Given this list of marker genes Cxcl1, Acp3, Fabp5, Atp8b4, Slc44a2, Faf2, H2-M3, H2-Q6, Rab5b, Cat (NCBI Gene Id 269322), Cnn2, Arhgap9, Psmd3, Prss3, Fuca1, Cap1, Cpne3 (copine III), Tarm1, H2-M10.1 (histocompatibility 2, M region locus 10.1), Gmfg, Fpr1 (NCBI Gene Id 14293), Rab24, Dync1li1, Pdxk, Diaph1, Adgre5, Fcgr4, Defa41, Pira2, Csnk2b, Rab7, Pkp1, Rac1 (Rac family small GTPase 1), Kcmf1, A1bg, Prg2, Creg1, Elane, Srp14, Ttr, Psmd6, Pirb, Itgav, H2-Q1, Cpne1 (copine I), Snap23, Rap1a, Sell, Itgax (NCBI Gene Id 16411), Gca, Bpi, Aldoc, H2-Q4, Gsn, Pafah1b2, Serpinb3d, Vnn1 (vanin 1), Hrnr, Capn1 (calpain 1), Dnajc13, Mme, Bst2, Oscar, Defa38, Plekho2, Cystm1, Tcirg1, Ftl2-ps, Lta4h, Rab5c, Hbb-bt, H2-M10.6, Psmd2, Ampd3, Nme2, AY761185, Defa24, Gstp2, Hebp2, Aga, Aldh3b1, Orm2, Ifi204, Ubr4, Ptx3, Psmd14, Rab44, Actr2, Defa36 (defensin, alpha, 36), S100a8, Apaf1, Cst3, Lilra6 (NCBI Gene Id 18726), Psen1, Defa26, Vamp8, Prcp, Copb1, Cfd, Pecam1, Hgsnat, Mif, Crispld2 (cysteine-rich secretory protein LCCL domain containing 2), Psma2, Mvp, Acaa1b, Clec5a, Olr1, Try4, Cd63, Man2b1, Ptpn6, Defa2, Stk11ip, Mlec, Lyz2, Huwe1, Serpinb12, Ggh, Pgm2, Cd55, Ear1, Defa25, Svip, Ckap4, Kpnb1 (karyopherin subunit beta 1), Ifi205 (interferon activated gene 205), Impdh1, Aprt, Serpina3f, Eef1a1, Ptprb, Ahsg, Defa43, Pnp, Cxcr1, Nhlrc3, Cd59b, Tubb4b, Lair1, Defa3, Cd53, Cd47, Vapa, Arpc5, Ppbp, Psap, Magt1, Rab10, Actr1b, Frk, Dock2, Defa42, Bst1, Naprt, Defa29, Pira13, Padi2, Grn, Fcna, Psmd12, Manba, Atp6v0c, Bri3, Dera, Cyba, Cdk13, D1Pas1, H2-T10, Ghdc, Hspa1b, Cxcr2, Hspa1a, Aldoa, P2rx1, Prkcd, Impdh2, Dsc1, Defa20, Rnaset2a, Prss1, Ctsc, Gm2a, H2-Q2 (NCBI Gene Id 497653), Atp11b, Cd33, Dgat1, Prss3l, Eef2, Dsn1, Ist1, Timp2, Chi3l1, Ptprj, Cant1, Vps35l (NCBI Gene Id 71517), Ptprn2, Psmd13, Dynlt1f, Itgb2, Lamtor2, Orm1, Commd9, Ptprc, Npc2, Mgam, Atp6ap2, H2-Q10, H2-M1, Try5, Mpo, Mmp9, Tlr2, Sptan1, Defa23, Golga7, Snap25, Atp6v0a1, Nit2, Cyfip1, Try10, Slc27a2, Psmc3, Ap2a2, Dynlt1a, Tspan14, Ptafr, Pycard, Gpi1, Vcl, Slc11a1, Xrcc6, Rock1, Erp44, H2-M9, Pygl, Ddost, Tmem179b (NCBI Gene Id 75392), Gyg1, Agpat2, Psmd11, Serpinb3b, Actr10, Nfkb1, 2310033P09Rik, Rhof, Prdx6, Slpi, Orm3, Frmpd3, Txndc5, Dpp7, Prss2, Alad, Stk10, Cd300c2, Mgst1, Stbd1, Gaa, Pdap1, Stom, Gstp1, Itgam, Rab3a, Jup, Defa39, Gsdmd, Prg3, Tubb5, Serpinb3c, Pgam1, H2-M10.5, Mndal, Neu1, Ctsd, Rhoa, Defa34, Pglyrp1, Scamp1, Dnajc5, Siglece, Enpp4, Pkm, Dnajc3, Arsb, Acly, Serpina1c, Ctsz, Pgrmc1, Fuca2, Ncstn, Defa27, Flg2, H2-M10.3 (histocompatibility 2, M region locus 10.3), Nbeal2, Cand1, Plaur, Serpinb10, Hmgb1 (high mobility group box 1), Rab37, Tollip, Igf2r, Defa35, Nfam1, Mmp25, Arg1, S100a9, Hp, Prss1l, Apeh, Cct8, Anxa2, Atp6v1d, Psg18, Lcn2, Ypel5, Iqgap2, Lamp1, Cfp, Anpep, H2-Q7, Mmp8, Defa31, Asah1, Slc15a4, Cd14, Cstb, Ctsb, Tmc6, Krt1, Rhog, Ano6, Ppia, Nckap1l, Fth1, Defa21, Lpcat1, Pygb, Sting1, Arl8a, Clec4n, C3, Cd36, Cyb5r3, Tbc1d10c, Slc2a3, Dynlt1c, Snap29, Cd44, Serpinb3a, Commd3, Psmb1, Ptges2, Mcemp1, Fcer1g, H2-K1, Dynll1, Hbb-bs, Dsp, Vat1, Cracr2a, Ap1m1, Ctsh, Rap2b, Dok3, Cd177, Chrnb4, Pigr, Gm5150, Aoc1, Ticam2, Qpct, Psma5, Tmem63a, H2-M10.2, Adam8, Tmbim1, Idh1, B2m, Xrcc5, Epx, Serpinb6a, Plau, Psmd1, Slc2a5, Sdcbp, Hk3, Defa40, Serpinb1a, Hspa8, Agl (NCBI Gene Id 99740), Ms4a3, Tom1, Tmem30a, Ctsg, Slco4c1, Rab31, Cda, Rab18, Unc13d, Ormdl3, Cybb, H2-T23, Hvcn1, Trpm2, Pgm1, Alox5, Mapk14, Fcnb, Serpina1b, Lilra5, Rnase2a, Cab39, Fgl2, Defa17, Psg22, H2-M11, Retn, Surf4, Cotl1, C3ar1, Defa32, H2-M2, Pnp2, Gdi2, Rab6a, Gpr84, Defa37, Ear6, Rab9b, Adgrg3, Psmd7, Psmc2 (NCBI Gene Id 19181), Arsa, Ctss, Pa2g4, Olfm4, Cd68 (CD68 antigen), Hexb, Rap2c, Kcnab2, Glipr1, Dynlt1b, Hmox2, Psmb7, Defa22, Hpse, Cct2, Fpr2, Lamtor1, Atp11a, Trappc1, Clec12a, Bin2, Dsg1a, Ddx3x, Arhgap45, Defa28, Ceacam2, Gns, Ear10, Cmtm6, Tyrobp, Psg29, Sorbs2, Atad3a, B4galt1, S100a11, Rnaset2b, Atg7, Prdx4, Ceacam1, Dnase1l1, Degs1, Ctsa, Hsp90ab1, 1600012H06Rik, Defa5, Chit1, Armc8, Fcgr2b, Qsox1, Atp8a1, Iqgap1, Tnfaip6, Defa30, Camp, Ndufc2, Lrrc7, Rab14, Gusb, Tnfrsf1b, Ear2, Pfkl, Fgr, Pira12, Prtn3, Adam10, Syngr1, Ifi211, Ltf, Sirpa, Mospd2, Folr2, Rab4b, Nfasc, Rab27a (NCBI Gene Id 75673), Ilf2, Hsp90aa1, Ostf1, Abca13, Lamtor3, Clec4d, Galns, Ear14, Cep290, Calm4, Itgal (integrin alpha L), Rnase2b, Cd93, H2-M5, Mapk1, H2-T22, Dync1h1, Gla, Glb1, Rap1b, Plac8, Lamp2 (lysosomal-associated membrane protein 2), H2-M10.4, C5ar1, Rab3d, Cpped1, Vcp, here is a description of the gene set: Mouse Gene Set: REACTOME_NEUTROPHIL_DEGRANULATION Neutrophil degranulation species: Mus musculus